Given this list of marker genes Tuba1b, Cpd, Cav1, Ass1, Cdc14a (NCBI Gene Id 229776), Tcf7l1, Timp2, Bmp4, Ccnd1, Phxr4, Abcg1, Gpx1, Ccn1, Amigo2, Hck, Apln, Cryab, F2r, Nars2, Cxcl12 (NCBI Gene Id 20315), Cnn2, Ramp2, Edn1, Rras2, Arrb1, Mylip, Cpe, Zmat3, here is a description of the gene set: from publication Gross C, Dubois-Pot H, Wasylyk B (PMID 17704799) The ternary complex factor Net/Elk3 is downregulated in hypoxia and participates in the induction by hypoxia of several genes, including c-fos, vascular endothelial growth factor and egr-1. However, the global role of Net in hypoxia remains to be elucidated. We have identified, in a large-scale analysis of RNA expression using microarrays, more than genes that are regulated by Net in hypoxia. In order to gain insights into the role of Net in hypoxia, we have analysed in parallel the genes regulated by HIF-1alpha, the classical factor involved in the response to hypoxia. We identified about genes that are regulated by HIF-1alpha in hypoxia. Surprisingly, when we compare the genes induced by hypoxia that require either Net or HIF-1alpha, the majority are the same (75%), suggesting that the functions of both factors are closely linked. Interestingly, in hypoxia, Net regulates the expression of several genes known to control HIF-1alpha stability, including PHD2, PHD3 and Siah2, suggesting that Net regulates the stability of HIF-1alpha. We found that inhibition of Net by RNAi leads to decreased HIF-1alpha expression at the protein level in hypoxia. These results indicate that Net participates in the transcriptional response to hypoxia by regulation of HIF-1alpha protein stability. Mouse Gene Set: GROSS_ELK3_TARGETS_UP Genes up-regulated in SEND cells (skin endothelium) at normal oxygen (normoxia) conditions after knockdown of ELK3 by RNAi. species: Mus musculus